Given this list of marker genes PPP3R2, PPP3CA, PPP3CC, MIR200C, PPP3CB, MIR208A, PPP3R1, MIR208B, here is a description of the gene set: Any process that stops, prevents or reduces the frequency, rate or extent of calcium ion import across plasma membrane. Human Gene Set: GOBP_NEGATIVE_REGULATION_OF_CALCIUM_ION_IMPORT_ACROSS_PLASMA_MEMBRANE studied in species Homo sapiens